Given this list of marker genes KHDRBS1, PWWP2A, ATP6V1B2, USP40, TXNDC17, RWDD4, DYNC2I2, CUL2, NAA15, IL4I1, CAPRIN1, ZNF585A, KLHDC4, NUP155, ALAS1 (NCBI Gene Id 211, 5'-aminolevulinate synthase 1), EIF5A2, ATP5MF, NDUFS5, RGS10, MEMO1, PPP1R14B, C19orf25, PIH1D1, GTPBP3, PCBP2, PAICS, MED17, POLR2E, NEDD8, QNG1, COX6B1, PEX7 (peroxisomal biogenesis factor 7), SUCLA2, MRPL19, GLRX5, RAP1A, MED8, HARS1, MPHOSPH6, ALKBH2, ACBD6, DPP9, MRPL34, NDUFS1, VCPKMT, NUP205, YARS1, SUB1, POGLUT2, TIMM17B, ECHDC1, SLC7A1, PCNA (NCBI Gene Id 5111), NLE1, SRSF3, PCCB, TFDP1, SNF8, ARL6, PRDX2, RNPS1, CCDC90B, NPM1, TMEM216, ZNF202, RSL1D1, P4HB, IPPK, CLPX, HSD17B10, JPT2, RAB23, ATF2, BCL7C, PWP2, DDX31, SLC7A5, FKBPL, AHCYL1, PCMT1, GFER, WDR83, AHSA1, NCBP2AS2, ZNF566, POLR1E, ELOC, LSM6, GET3, NDUFV1, LCMT2, LMOD3, FASTKD2, MRPL52, C6orf136, CNOT9, TXLNA, RCE1, NUP35, INTS15, SUPT6H, CSNK2B, RPSA, DHX15, SLC25A6, SF3A2, TPD52L2, TCF4, ADM, MRPL44 (NCBI Gene Id 65080), MDH1 (NCBI Gene Id 4190), NUP107, SNAI3, DNMT3L, PBDC1, SNRPB, GTF2F2, EXOSC6, MRPS6, GGH, SAR1B, NSUN2, P4HA1, SRFBP1, HBS1L, PRORP, LIG3, MCM8, AFG3L2, MTX2, PHF5A, MICOS13, SNX12 (NCBI Gene Id 29934), FAM72A, CMTR2, SLC16A1, DHX37, RBIS, TMED7, CYB561D2 (cytochrome b561 family member D2), BTG3, LIPT1, FOCAD (NCBI Gene Id 54914), POP7 (NCBI Gene Id 82671), TUBB4B, PPAT, UBE2J2, EIF4E, PHGDH, PEX10, ORAI1, RFC4, ABHD11, NUTF2, PIGY, EWSR1, TIMM44 (NCBI Gene Id 93111), CD2BP2, TRA2B, ARHGAP23, PPA2 (NCBI Gene Id 92033), MCM5, UTP25, BTAF1, RCC1L, PARS2, TRMT10C, ZC3H15, ETFA, TEN1, NDUFA2, MAP2K4, MMGT1, EED, KYAT3, GLMN (glomulin, FKBP associated protein), TAF2, JADE3, PTGES3, BLMH, JOSD2, LRRC59, MAFG, SH2D2A, CHCHD1, ADO, TUBB, NDUFS2, TIMM13, TMEM69, ARL5A, MACROD1, RBM17, AKR1B1 (NCBI Gene Id 231), COG2, PGAM5, ARV1, PIN1, ELP3, here is a description of the gene set: species: Homo sapiens Human Gene Set: GSE22432_PDC_VS_TGFB1_TREATEDCOMMON_DC_PROGENITOR_UP from publication Felker P, Seré K, Lin Q, Becker C, Hristov M, Hieronymus T, Zenke M (PMID 20881193) Genes up-regulated in dendritic cells: plasmacytoid versus cultured common progenitors treated by TGFB1 for 4h. Dendritic cells (DCs) in lymphoid tissue comprise conventional DCs (cDCs) and plasmacytoid DCs (pDCs) that develop from common DC progenitors (CDPs). CDPs are Flt3+c-kitintM-CSFR+ and reside in bone marrow. Here we describe a two-step culture system that recapitulates DC development from c-kithiFlt3-/lo multipotent progenitors (MPPs) into CDPs and further into cDC and pDC subsets. MPPs and CDPs are amplified in vitro with Flt3 ligand, stem cell factor, hyper-IL-6 and insulin- like growth factor-1. The four-factor cocktail readily induces self-renewal of MPPs and their progression into CDPs and has no self-renewal activity on CDPs. The amplified CDPs respond to all known DC poietins and generate all lymphoid tissue DCs in vivo and in vitro. Additionally, in vitro CDPs recapitulate the cell surface marker and gene expression profile of in vivo CDPs and possess a DC-primed transcription profile. Transforming growth factor-β1 (TGF-β1) impacts on CDPs and directs their differentiation towards cDCs. Genome-wide gene expression profiling of TGF-β1-induced genes identified transcription factors, such as interferon regulatory factor-4 (IRF-4) and RelB, that are implicated as instructive factors for cDC subset specification. TGF-β1 also induced the transcription factor inhibitor of differentiation/DNA binding 2 (Id2) that suppresses pDC development. Thus, TGF-β1 directs CDP differentiation into cDC by inducing both cDC instructive factors and pDC inhibitory factors.